The following is a description of a gene set: from publication Chen Y, Wang X (PMID 31504780) Genes predicted to be targets of miRBase v22 microRNA mmu_miR_365_1_5p in miRDB v6.0 with MirTarget v4 prediction scores > 80 (high confidence targets). Mouse Gene Set: MIR_365_1_5P studied in species Mus musculus, and this is the list of marker genes: Tspyl5, Acadsb, Mapt, Sim2, Ovca2, Atp2c1, Nfasc, Dnajb2, Hmga2, S2bpcox16, Epha7, Clip3, Zfp91, Prdm6, Vcan, Phc2, Kics2, Slc39a2 (NCBI Gene Id 214922), Sugp1, Cox16, Slitrk1, Glycam1, Stox2, Gpr152, Ubr3, Ccdc47, Slc37a2, Hmmr, Ebf1, Extl2, Sirt1, Zfp36, Pwwp3b